The following is a description of a gene set: studied in species Homo sapiens An abnormal deviation from normal levels of IgA immunoglobulin in blood. Human Gene Set: HP_ABNORMAL_CIRCULATING_IGA_CONCENTRATION Abnormal circulating IgA concentration, and this is the list of marker genes: UNG, ARPC5, SEC61A1, TOM1, CCND1, IGKC, KNSTRN, PIK3CG, HLA-DQB1, CARD10, RAG2, CAVIN1, ORAI1, IRF2BP2, RFXAP, HLA-DQA1, SASH3, ATM, TNPO3, PRIM1, RFX5, NFKBIA, TYMS, ALG12, LAT, PGM3, IRF1, TNFRSF13C (TNF receptor superfamily member 13C), WAS, IPO8, MMEL1, AICDA, PLCG2 (NCBI Gene Id 5336), CD40LG, LCK, MTOR, TNFRSF11A, CARD11, CSNK2A1, ITCH, RAI1, IL2RG, CD40, TCF3, STAT2, LRBA, GTF2H5, CASP10, PIK3R1, STING1, RNF168, NSD2, DCLRE1C, CD19, PSMB8, DEAF1, CD79B, CBLB, NFE2L2, IRF5, ICOS, CTBP1, ZBTB24, FAS, SPIB, POMP, CR2, IVNS1ABP, IL6ST, CTLA4, ZNF341, SYK, CD247, BACH2, ATP6AP1, CD3D, NELFA, PIK3CD, CASP8, DOCK11, POLD1, PMM2, PIGT, PSMB10, IGHG2, MVK (NCBI Gene Id 4598), OTULIN, IL7R, NLRP1, KDM6A, CD3E, KMT2D, TNFSF15, DNMT3B, STIM1, FASLG, IL2RA, ADA, MOGS, RAG1, CPLX1, NFKB2 (nuclear factor kappa B subunit 2), IL12A, BLNK, IGLL1, PIGG, PDCD1, LIG1, LYN, IQSEC2, B2M, REL, TNFRSF13B, BLM, SPI1, BTK, IL12RB1, IKBKG, LETM1, JAK3, FLII, TCN2, POU2AF1, MAP3K14, RASGRP1, PTPRC